Given this list of marker genes SLC34A2, EBP, ENPP1, LEMD3 (NCBI Gene Id 23592), DDR2, ABCC6, here is a description of the gene set: species: Homo sapiens Human Gene Set: HP_ABNORMAL_CALCIFICATION_OF_THE_CARPAL_BONES Abnormal calcification of the carpal bones